Given this list of marker genes SLC35A1, here is a description of the gene set: Reactome Pathway: Defective SLC35A1 in sialic acid metabolism causes congenital disorder of glycosylation 2F (CDG2F) part of: SLC transporter disorders The human gene SLC35A1 encodes the CMP-sialic acid transporter which mediates the antiport of CMP-sialic acid (CMP-Neu5Ac) into the Golgi lumen in exchange for CMP. Defects in SLC35A1 are the cause of congenital disorder of glycosylation type 2F (CDG2F; MIM:603585), characterised by under-glycosylated serum proteins. CDGs are a family of severe inherited diseases caused by a defect in protein N-glycosylation. These multisystem disorders present with a wide spectrum of phenotypes such as disorders of nervous system development, psychomotor retardation, dysmorphic features, hypotonia, coagulation disorders and immunodeficiency. species: Homo sapiens